Given this list of marker genes SYNE2, UGT2B28, CLMN, SLC22A3, ITPR3, DHCR7, GHRHR, PSEN1, SMPD4, PTGS2, GUCY2D, CPTP, LTC4S, LRPPRC, DMPK, TMEM53, SYNE1 (NCBI Gene Id 85448), NUTF2, EMD, SIGMAR1, NAV3, NUCB2, RETSAT, TMEM109 (NCBI Gene Id 79073), BOK, SNCA, ITPRIP, SYNE3, ENO1, SYNE4, GUCY2F, KASH5, TRAPPC2B, here is a description of the gene set: Human Gene Set: GOCC_NUCLEAR_OUTER_MEMBRANE The outer, i.e. cytoplasm-facing, lipid bilayer of the nuclear envelope; continuous with the endoplasmic reticulum of the cell and sometimes studded with ribosomes. studied in species Homo sapiens